The following is a description of a gene set: Neighborhood of PTPN4 protein tyrosine phosphatase, non-receptor type 4 (megakaryocyte) in the GNF2 expression compendium studied in species Homo sapiens Neighborhood of PTPN4 Human Gene Set: GNF2_PTPN4, and this is the list of marker genes: PTPN4, NCR3, ITGAL, NPRL2, ZAP70, KIR2DS2, IL2RB (interleukin 2 receptor subunit beta), FYN, GNLY, PTGDR, GZMM, CST7, RORA, KLRD1, KLRB1, RASSF1, SUN2, GZMA, CD247, CD7, MYOM2, TTC38, RUNX3, GNPTAB, KLRF1, IL18RAP, ADGRG1, PTGER2, PRF1, TBX21, BTN3A3, KLRC3, SPON2, ARHGEF3, PLAAT4 (NCBI Gene Id 5920), KLRK1, NKG7 (NCBI Gene Id 4818), MATK, CCL4, CD160, GZMH, CTSW, GPR65, PRKCH, S1PR5, ARL4C, ABHD17A, RAB29, XCL2, JAK1